The following is a description of a gene set: studied in species Homo sapiens from publication Lee MS, Hanspers K, Barker CS, Korn AP, McCune JM (PMID 15210650) Human Gene Set: GSE1460_DP_THYMOCYTE_VS_NAIVE_CD4_TCELL_CORD_BLOOD_UP Genes up-regulated in comparison of CD4 CD8 thymocytes versus naive CD4 T cells from cord blood. Subpopulations of human fetal thymocyte and circulating naïve T cells were obtained through FACS sorting, including CD3-CD4+CD8- intrathymic T progenitor cells (ITTP), CD3intCD4+CD8+ \double positive\ thymocytes (DP), CD3highCD4+CD8- \single positive\ thymocytes (SP4), CD3+CD4+CD8-CD45RA+CD62L+ naive T cells from cord blood (CB4+), and CD3+CD4+CD8-CD45RA+CD62L+ naive T cells from adult blood (AB4+)., and this is the list of marker genes: GOT1, HNRNPA0, HBS1L, BAHCC1, DHTKD1, AGPS, TUBB4B, DDX46, SCFD1, EDRF1, RBBP4, NCAPD2, KIF22, ATP5F1C, RFX5, CDV3, SLC35E3, HERC2P3, HADH, MSH6, PCBP2, NAPG, SPDL1, EDEM1 (ER degradation enhancing alpha-mannosidase like protein 1), DGKE, TPX2, NUP155, DYNLL1, CENPU, KIF2C, NPLOC4, C1QTNF3, VPS52, METTL3, CORO2A, POLQ, NSD2, TRO, NRDC, SEC61A2, FOXM1, PSMA6, OIP5, NCAPG2, ST3GAL5, CDC45, PTEN, TBC1D19, MDM4, DYNC1I2, CCNA2, PMS2P5, AVEN, PLK4, RASSF1, VANGL1, GGH, ITFG2, SNRPE (NCBI Gene Id 6635), TCEAL9, ITGB3BP, CTNNBL1, PUDP, HDGF, NINL, GPR19, MTMR1, PSIP1, PIK3C3, SMARCA4, GUSBP11, INTS7, SMAD1, GAB2, UBA2, SLC11A2, TACC1, MPC2, MBTPS2, PDCD6IP, PARK7, SMAD6, FARP1, H2BC4 (NCBI Gene Id 8347), LETM1, SREK1IP1, KCNK5, SOX4, CLGN, SSR1, HNRNPDL, CRNKL1, GRAMD4, TXNRD1 (thioredoxin reductase 1), ZNF177, AP5Z1 (adaptor related protein complex 5 subunit zeta 1), CBX5, MPHOSPH9, GUCY1B1, HNRNPA2B1, SOCS5, SH2D1A, CKS2, GRK3, ATIC, UBR7, GOLGA3, CD99, GPSM2, IDH1, ENSA, LINC00115, RFC1, C2CD2L, KIF13B, PAXBP1, DNAJC15, SMC2, SSRP1, CD38, KIF14, LIMK2, ARFGAP2, PELO, UBE2E3, CLDN1 (claudin 1), LYRM1, GNG5, ZEB1, AAGAB, GFI1, HDAC7, MTMR4, ATP5F1A, MAGED1, NUP62CL (NCBI Gene Id 54830), TESMIN, UCP2, GNL2, IL3, FIRRM, AQP3, DAD1, BARD1, PPME1, ARMH3, PKD2, KPNA6, SECISBP2, H2AZ2, TSPOAP1, FOCAD, TXNL4A, CHD9, ZNF271P, IFT81, PGRMC1, VOPP1, SLC25A14, LAMTOR5, TSPAN9, BFAR, SRP9, LRRC1, RNASEH2A, PLXND1, RTL8C, PLPP3, TEX10, RNF121, TOR1A, RBBP7, DLAT, POLR3C, ULK1, PPIA, MPP1, KIFBP, CXADR, DMAC2L, HMGB3P1, MIS18A, RNF8, PSMA2, NUDC, TIMP2, CENPE, MBD1, TSG101, HTATSF1, ZNF638, GABARAP, FEN1, EZR (ezrin), STAG3, KCNJ2, NCBP1 (NCBI Gene Id 4686), C8orf33, CKS1B, KRT8